Given this list of marker genes Cd36, Pof1b, Mpzl2, Tmt1a, Aox3, Rpl17, Galnt13, Dsc2, Aqp4, Emb, Fut9, Fabp4, Maob, Tesc, Arsk, Gsto1, here is a description of the gene set: Epithelial organs, including the lung, are known to possess regenerative abilities through activation of endogenous stem cell populations, but the molecular pathways regulating stem cell expansion and regeneration are not well understood. Here we show that Gata6 regulates the temporal appearance and number of bronchioalveolar stem cells (BASCs) in the lung, its absence in Gata6-null lung epithelium leading to the precocious appearance of BASCs and concurrent loss in epithelial differentiation. This expansion of BASCs was the result of a pronounced increase in canonical Wnt signaling in lung epithelium upon loss of Gata6. Expression of the noncanonical Wnt receptor Fzd2 was downregulated in Gata6 mutants and increased Fzd2 or decreased beta-catenin expression rescued, in part, the lung epithelial defects in Gata6 mutants. During lung epithelial regeneration, canonical Wnt signaling was activated in the niche containing BASCs and forced activation of Wnt signaling led to a large increase in BASC numbers. Moreover, Gata6 was required for proper lung epithelial regeneration, and postnatal loss of Gata6 led to increased BASC expansion and decreased differentiation. Together, these data demonstrate that Gata6-regulated Wnt signaling controls the balance between progenitor expansion and epithelial differentiation required for both lung development and regeneration. species: Mus musculus Mouse Gene Set: ZHANG_GATA6_TARGETS_UP Genes up-regulated after cre-lox knockout of GATA6 in airway epithelium. from publication Zhang Y, Goss AM, Cohen ED, Kadzik R, Lepore JJ, Muthukumaraswamy K, Yang J, DeMayo FJ, Whitsett JA, Parmacek MS, Morrisey EE (PMID 18536717)